Given this list of marker genes MYH3, L1CAM, PADI2, GRAMD1B, CTNND1 (NCBI Gene Id 82168), ME1, CACNA1D, SPRR1B, LAMA4 (laminin subunit alpha 4), GABRR1, CCHCR1, CNTNAP2, CYP11A1, LY6E (NCBI Gene Id 7999), COL1A1, CD180, CLP1, TNNI1, PKD2, S100A1, POU3F4, PAGE1, HTR2A (5-hydroxytryptamine receptor 2A), PARD3, HSD3B1, IRF6, IGSF1, F2RL1, LZTR1, CFH, MRC2, NPHP4, FUT7, SELP, PDE4DIP, BCAM, DCHS1 (dachsous cadherin-related 1), CAMK1G, LMO2, SHBG, ETV2, ADGRL2, ZBTB22, EPYC, USH1C, GJA8, DCLRE1A, PDPN, WNT2, ATP4A, MYCNOS, KPLCE, ITGA4 (integrin subunit alpha 4), TACR3, CLDN4, SLC19A2, PTPRZ1, PBX1, LGALS9, GUCA1B, MX1, F7, NEDD4 (NCBI Gene Id 4734, NEDD4 E3 ubiquitin protein ligase), MYO1A, ANG, GPRC5B, KRT1, HOXB13, ZNF592, HPCA, SERPINA5, SORT1, ZNF821, SCARB1, ERC2-IT1, NPTX1, HNF1B, CYP17A1, INPP5F, ASCL1, IGSF6, RIMS3, LAMA3, AVPR1A, CITED1, CHGA, SLCO3A1, SPAM1, UNC13B, FMO1, ARHGEF11, PCSK2, MED14, MYBPC1, EOLA1-DT, HMHB1, CADM4 (cell adhesion molecule 4), BGN, TIMP2, ZP2, UPK2 (uroplakin 2), CDKL5, TGFBR2, MMP7, ZNF248, DNAH17, CLCN5, B4GALNT1, MIR9-1HG, MMP11, FAM76A, RAB3B, MYO10, MAU2, KLKB1, KDELR3, PDE6A, THBD, TMEM8B, BASP1, POLR3D, ATP6V1G2, PLA2G4C (phospholipase A2 group IVC), CASP10, KCNJ2, MAP4K4, WHAMM, ADGRV1, KLF5, KCNN3, STON1, CALCA, CAMK2G, TGM2, TLE2, DOCK9, PGAM2, CRADD, TNFSF12, MCF2L, TIMP3, RNASE3, SPOCK1 (SPARC (osteonectin), cwcv and kazal like domains proteoglycan 1), KLK8, AKAP3, ECE1, GPR12, GRINA, KCNN1, ST6GALNAC2, EPHA1 (NCBI Gene Id 2041), APOD, P2RY2, ANGPT1, SMAD9, NTRK3, RIMBP2, HOXC5, ADAMTSL2, ZNF185, OVOL1, SLITRK5, SYCP1, ICAM4, DLGAP2 (DLG associated protein 2), LAMC1, PCDHB11, FCGR2B (NCBI Gene Id 2213), CDK18, RAB40AL, SPRR2C, CREB5, AQP1, ASIP, DEFB1, GPR171, MCAM, PTH2R, KALRN, MINAR1, GRM3, RSC1A1, TRIM44, CRTC1, CRACDL, PGR, KIF3B, OR5I1, CCL20, ZNF529, AGXT, P2RX7 (purinergic receptor P2X 7), ATP2B2, TAGLN, TCTA, BMP7, GUCA2B, here is a description of the gene set: Genes up-regulated in pre-B cells: STAT5 knockout versus wildtype. Human Gene Set: GSE24814_STAT5_KO_VS_WT_PRE_BCELL_UP In order to investigate the function of STAT5 in ALL, we isolated bone marrow cells from STAT5 fl/fl mice and transformed them with BCR-ABL1. In a second transduction the BCR-ABL1 driven pre-B cells were transformed either with CRE-GFP or empty vector control (GFP) and subjected to gene expression analysis. from publication Hurtz C, Hatzi K, Cerchietti L, Braig M, Park E, Kim YM, Herzog S, Ramezani-Rad P, Jumaa H, Müller MC, Hofmann WK, Hochhaus A, Ye BH, Agarwal A, Druker BJ, Shah NP, Melnick AM, Müschen M (PMID 21911423) species: Homo sapiens